Given this list of marker genes BAG3, COL6A3, MORC2, GAA, COL6A2, PMP22, DNAJB4, TRPV4, IGHMBP2, TPI1, CHRNA1, COL12A1, SLC52A3, REEP1, COL6A1, TTN, MEGF10, here is a description of the gene set: Human Gene Set: HP_DIAPHRAGMATIC_WEAKNESS species: Homo sapiens A decrease in the strength of the diaphragm. Diaphragmatic weakness